Given this list of marker genes CHRNG, SHOX, IDH1, IDH2, EXT2, ALX4, EXT1, PTPN11, FGFR3, COL2A1, ACAN, AKT1, IPO8, RAD21, MSX2, PTEN, ATP7A, CHD6, COL11A2, TRPS1, PHF21A, here is a description of the gene set: An exostosis is a benign growth the projects outward from the bone surface. It is capped by cartilage, and arises from a bone that develops from cartilage. Human Gene Set: HP_EXOSTOSES species: Homo sapiens Exostoses